Given this list of marker genes Lgmn, Sec1, Rac1, Rhoj, Foxc2, Bcas3, Map2k3, Pdpk1, Pik3cd, Gpld1, Igf2, Akt3, Prkca, Ets1, Pdgfb, Adora2b, Akt1, Bcar1, Egf, Dicer1, Plcg1, P2rx4 (NCBI Gene Id 52272), Fut1, Itgb1bp1, Prl2c2, Map3k3, Fgf2, Zc3h12a, Adgra2 (adhesion G protein-coupled receptor A2), Calr, Pdcd6, Nrp1, Amotl1, Vegfa (vascular endothelial growth factor A), Gata2 (GATA binding protein 2), Ccbe1, Sash1, Hspb1 (NCBI Gene Id 15507), Wnt7a, Atoh8 (NCBI Gene Id 71093), Prkd2, Jcad, Plpp3, Stat5a, Emc10, Pik3cg, Abl1, Bsg, Anxa1, Bmp4, Gab1, Zfp580, Met, Prox1, Tek, Plk2, Atp5f1a, Col18a1, Flt4, Sp1, Hdac7, Itgb3, Gpi1, Tmsb4x, Rock2, Lcn2, Srpx2, Cib1, Shh, Fgf18, Igf1, Gata3, Kdr, Snai2, Tgfb1, Ptk2b, Angpt1, Smoc2, Anxa3, Thbs1, Pik3cb, Rras, Nfe2l2, Gfus, Prkd1, Hif1a, Fgf16, Nos3 (NCBI Gene Id 71933), Angpt4, Nus1, Vegfc, Amot, Rin2, Tmem201, Sirt1, Fgfr1, Agt, Sparc, Tgfbr3, Fgfbp1, Sema5a, Fgf1, Grn, Hmox1, Hdac9, Alox12, Plg, Hmgb1 (NCBI Gene Id 15289), Pik3c2a, Adam17 (NCBI Gene Id 236174), Cd40, Atp5f1b, Rhob, Wnt5a, Foxp1, Ptgs2, here is a description of the gene set: Any process that increases the rate, frequency, or extent of the orderly movement of an endothelial cell into the extracellular matrix to form an endothelium. Mouse Gene Set: GOBP_POSITIVE_REGULATION_OF_ENDOTHELIAL_CELL_MIGRATION studied in species Mus musculus